The following is a description of a gene set: Genes upregulated in subsets of cells of a given type within various tumors from publication Gavish A, Tyler M, Greenwald AC, Hoefflin R, Simkin D, Tschernichovsky R, Galili Darnell N, Somech E, Barbolin C, Antman T, Kovarsky D, Barrett T, Gonzalez Castro LN, Halder D, Chanoch-Myers R, Laffy J, Mints M, Wider A, Tal R, Spitzer A, Hara T, Raitses-Gurevich M, Stossel C, Golan T, Tirosh A, Suvà ML, Puram SV, Tirosh I (PMID 37258682) In this study, an extensive analysis was conducted to define meta-programs (MPs) capturing intra-tumor heterogeneity across a spectrum of tumor types. The approach utilized non-negative matrix factorization (NMF) to analyze each cell type separately within individual tumor samples. This involved the analysis of malignant cells, macrophages, fibroblasts, endothelial cells, epithelial cells, T-cells, and B-cells. NMF was executed with varying parameter values (K=4, 5, 6, 7, 8, 9), thereby generating 39 programs for each cell type per sample. Each NMF program was summarized by the top genes based on NMF coefficients.\nRobust MPs were then delineated for each cell type using a set of stringent criteria, including recurrence within the same tumor, similarity to programs in other tumors, and non-redundancy within a tumor. Subsequently, these robust NMF programs were clustered (per cell type) based on Jaccard similarity, leading to the identification of MPs associated with each cell type.\nTo enhance the quality of the MPs, a refinement steps were undertaken, involving the removal of MPs suspected of reflecting low-quality data (with an overrepresentation of ribosomal proteins or mitochondrial-encoded genes), single-study inclusion, or similarity to miss-annotated cell types. species: Homo sapiens Human Gene Set: GAVISH_3CA_METAPROGRAM_CD8_T_CELLS_MEMORY_NAIVE_1, and this is the list of marker genes: FOSB, GPR183, IL7R, EIF3E, DNAJB1, RGS2, MYADM, TNFAIP3 (TNF alpha induced protein 3), TUBB4B, YPEL5, NR4A2, TOB1, DNAJA1, CXCR4, KLF6, DUSP2, BIRC3, FAM177A1, NFKBIA, JUNB, SNHG8, CREM, CD69, RGS1, SLC2A3, RGCC, TUBA4A, IER2, PIK3IP1, TMEM123, ANXA1, DUSP1, SELL, PIK3R1, PPP1R15A, ZFP36, TXNIP, BTG2, CD55, FOS, LTB, ZNF331, CCR7, LEPROTL1, TSC22D3, GZMK, LMNA, GADD45B, AREG, JUN